The following is a description of a gene set: Reactome Pathway: Evasion of Oxidative Stress Induced Senescence Due to Defective p16INK4A binding to CDK4 species: Homo sapiens part of: Evasion of Oxidative Stress Induced Senescence Due to p16INK4A Defects Missense mutations and small indels in the CDKN2A gene, which result in amino acid changes in p16INK4A that impair its ability to bind to CDK4, interfere with p16INK4A-mediated, oxidative stress-induced, cellular senescence.<br>Loss-of-function mutations in p16INK4A can also contribute to cancer by interfering with p16INK4A-mediated inhibition of NFKB signaling., and this is the list of marker genes: CDKN2A, CDK4